The following is a description of a gene set: from publication Jeffrey KL, Brummer T, Rolph MS, Liu SM, Callejas NA, Grumont RJ, Gillieron C, Mackay F, Grey S, Camps M, Rommel C, Gerondakis SD, Mackay CR (PMID 16474395) Genes down-regulated in comparison of dendritic cells (DC) versus macrophages. species: Homo sapiens Human Gene Set: GSE3982_DC_VS_MAC_DN In the present study we used Affymetrix oligonucleotide microarrays to produce gene transcription profiles for the major leukocyte types in humans. This comprehensive dataset enabled us to not only establish which genes were expressed in each leukocyte type, but also which genes were expressed in each subset after activation. The used of a comprehensive dataset of gene profiles from all the major human leukocyte subsets enabled a novel and powerful means for identification of genes associated with single leukocyte subsets, or different immune paradigms., and this is the list of marker genes: INCENP, VCP, CD101, IRF9, MYO6, HOXB2, FCGR1BP, RGS20, GRM3, FDX1, FCGR3B, GRM6, IGFBP1, PCBP1, SHCBP1, CCL7, AKIP1, COLEC12, JOSD1, ERC2, KCNJ1, LUZP4, VSIG4, NABP1, MTPAP, MON1B, TMX2, NELFCD, TIPRL, MED6, DCTN6, HHIPL2, CSF1, CLEC1B, SNCA, LNPEP, PBX1, ATP5MF, GDAP1, POLQ, CYP3A7, R3HCC1L, MAFB, CD163, CCNB2, AKR1C3, MMP7, TSC22D1, KIF4A, CTDSPL, GOLIM4, EMC3, RABGEF1, UBR7, SEC61G, SAR1A, THBS2, NCALD, SLCO1C1, UBE2L3, BUB1B, STAT3, RDX, UNC13B, MLF1, RANGRF, CTLA4, MFSD13A, STON1, TPX2, FMO6P, CENPA, GADD45G, RFC2, BCL2L2, SLC9A7, PLEK, TRIM9, NR1H4, INSM1, VNN2, COA7, OGFOD1, LETM1, RNASEH2B, ARL4A, FAM114A1, MKI67, PKMYT1, MMP2, NACC2, SERPINA1, HPGDS, ATP6V0D1, C1QA, ZNF106 (NCBI Gene Id 64397), CXADR, PAPPA2, CRTAP, DNAJC12, NOS2, SULT1C2, RRM2, ZNF287, RBM14, TSC22D3, BEGAIN, TPM3, HSD17B8, FBXL7, RND3, NT5E, TLR8, HERC6, PNP, ATP6V1B2, PIK3CG, ASPHD1, GSC2, POLA1, NUMB, CCNB1, ITGA8, CLEC5A, LIPG, CTSK, GNG12, AREL1, CDC14B, NXPH4, ADAM10, AGPS, WDR19, KRT37, CES1, BEX3, ENY2, HEG1, NIP7, SASH1, SORL1, CHRNB4, TFF3, HSD17B3, BAIAP3, SLC23A2, RNF128, FAM114A2, AMIGO2, STUM, NAV2, RAD51AP1, SLC44A4 (NCBI Gene Id 87892), AP1M2, GATA1, S100A2, GDF10, SLC2A5 (solute carrier family 2 member 5), IL9, PKIA (cAMP-dependent protein kinase inhibitor alpha), DNASE2B, WASF1, KIF13B, ASF1B, NME7 (NME/NM23 family member 7), SPATA6, C3AR1, OR10J1, CCKBR, AURKA, HFE, ORC1, UBL5, CENPE, PRKAA2, ATP10B, PNMA2, MTMR1, CCNA2, ZWILCH, PHACTR1 (phosphatase and actin regulator 1), NRN1, POLE2, ANOS1, TLR7, CCL2, DPP4, WWTR1, TGFBR1, ZNF281, BCAT1, ZDHHC3, APOH, MYO1D, ZNRF4 (zinc and ring finger 4), HMMR, FCN1, ITGA6, MPC2, MME